Given this list of marker genes EYA3, RPF1, STMN2, SLC2A4, ORM2, FGF9, ABCA1, TNFAIP8L1, BLM (BLM RecQ like helicase), GLMP, SPTLC2, TPST1, SF3A2, ZNF574, STX12 (NCBI Gene Id 23673), ANP32A, MMP17, ZFYVE16, MKLN1, ZFR2, MED10, PDXDC1, NFKB1, BAZ1B, NANS, AHCY, LRRC58, CAVIN2, ABCC3, PVALB, DNAJB11, CETN2, TCIRG1, CTCF, TIPARP, SLC2A1, LAMB3, NDUFS2, NXF1, DDA1, DMTN, HNRNPH2, SF3B5, FLCN, C4orf3, STK11, NOP58, PTCD3, USP22, UTP4, PPARA, CHCHD7, TSHB, SAMM50, ZMYM4, KCNN1, ORMDL3, PLD2, SERPIND1, NRBP2, PSMD14, MSI1, TMEM222, DNAJB6, GDI2, MAP1S, MNT, MKI67, EPOP, SALL3, NSD1, MYH3 (myosin heavy chain 3), SDC1, AKAP8, PKIA, MRPL50, RAP1GDS1, RNF19B (ring finger protein 19B), ZBTB14, CRYGB, AGRP, PDLIM1, CCDC6, S100PBP, COMT, E2F8, NF1, PGAP2, IFIT1B, SLC35C2, EPS15L1, SEMA4F, ZNF444, IGFBP4, MAP3K12, SLC16A2 (NCBI Gene Id 6567), TULP4, FBLN1, TBC1D15, SFR1, ICOS, CHD8, CNBP, OTUB1, SNRPB, HMOX2, VDAC2, FABP5, TSPAN33, VAMP1, HPD, RAP1B, CYBA, HP, HOXD4, NAALAD2, MCM3AP, AIP, MTRES1, EIF5B, CSNK2A2, NME3, NCOA1, MOV10, EGF, FASTKD5, HAND1, SGCE, TRIP12, UPK3B, EPB41L4B, SYPL1, MRPS5, HSD17B2, PIGA, PSD, CAPN6, PRKCD, PDLIM7, PDK4 (pyruvate dehydrogenase kinase 4), EIF2B4 (NCBI Gene Id 8890), PXMP2, NNT, SBNO1, ST8SIA1, GLDC, RANBP9, SFPQ, ZFAND6, NAA30, SKAP2, PCK2, UCP1, RMC1, TTC17, here is a description of the gene set: studied in species Mus musculus We combined large-scale mRNA expression analysis and gene mapping to identify genes and loci that control hematopoietic stem cell (HSC) function. We measured mRNA expression levels in purified HSCs isolated from a panel of densely genotyped recombinant inbred mouse strains. We mapped quantitative trait loci (QTLs) associated with variation in expression of thousands of transcripts. By comparing the physical transcript position with the location of the controlling QTL, we identified polymorphic cis-acting stem cell genes. We also identified multiple trans-acting control loci that modify expression of large numbers of genes. These groups of coregulated transcripts identify pathways that specify variation in stem cells. We illustrate this concept with the identification of candidate genes involved with HSC turnover. We compared expression QTLs in HSCs and brain from the same mice and identified both shared and tissue-specific QTLs. Our data are accessible through WebQTL, a web-based interface that allows custom genetic linkage analysis and identification of coregulated transcripts. Genes trans-regulated by the same QTL (quantitative trait loci) in brain and hematopoietic stem cells (HSC). Human Gene Set: BYSTRYKH_HEMATOPOIESIS_STEM_CELL_AND_BRAIN_QTL_TRANS from publication Bystrykh L, Weersing E, Dontje B, Sutton S, Pletcher MT, Wiltshire T, Su AI, Vellenga E, Wang J, Manly KF, Lu L, Chesler EJ, Alberts R, Jansen RC, Williams RW, Cooke MP, de Haan G (PMID 15711547)